The following is a description of a gene set: Cell cycle genes up-regulated in H1299 cells (lung cancer) after overexpression of either P53 or P73. When normal cells come under stress, the wild-type (WT) p53 level increases resulting in the regulation of gene expression responsible for growth arrest or apoptosis. Here we show that elevated levels of WT p53 or its homologue, p73, inhibit expression of a number of cell cycle regulatory and growth promoting genes. Our analysis also identified a group of genes whose expression is differentially regulated by WT p53 and p73. We have infected p53-null H1299 human lung carcinoma cells with recombinant adenoviruses expressing WT p53, p73 or beta-galactosidase, and have undertaken microarray hybridization analyses to identify genes whose expression profile is altered by p53 or p73. Quantitative real-time PCR verified the repression of E2F-5, centromere protein A and E, minichromosome maintenance proteins (MCM)-2, -3, -5, -6 and -7 and human CDC25B after p53 expression. 5-Fluorouracil treatment of colon carcinoma HCT116 cells expressing WT p53 results in a reduction of the cyclin B2 protein level suggesting that DNA damage may indeed cause repression of these genes. Transient transcriptional assays verified that WT p53 repressed promoters of a number of these genes. Interestingly, a gain-of-function p53 mutant instead upregulated a number of these promoters in transient transfection. Using promoter deletion mutants of MCM-7 we have found that WT p53-mediated repression needs a minimal promoter that contains a single E2F site and surrounding sequences. However, a single E2F site cannot be significantly repressed by WT p53. Many of the genes identified are also repressed by p21. Thus, our work shows that WT p53 and p73 repress a number of growth-related genes and that in many instances this repression may be through the induction of p21. studied in species Homo sapiens Human Gene Set: SCIAN_CELL_CYCLE_TARGETS_OF_TP53_AND_TP73_UP from publication Scian MJ, Carchman EH, Mohanraj L, Stagliano KE, Anderson MA, Deb D, Crane BM, Kiyono T, Windle B, Deb SP, Deb S (PMID 17982488), and this is the list of marker genes: SEPTIN9, JAG2, HRAS, SFN, NEDD9, GAS2L1, LTBP2, TP53, CDKN1A